The following is a description of a gene set: Mouse Gene Set: GOBP_MEMBRANE_RAFT_ORGANIZATION species: Mus musculus A process that is carried out at the cellular level which results in the assembly, arrangement of constituent parts, or disassembly of membrane rafts, small (10-200 nm), heterogeneous, highly dynamic, sterol- and sphingolipid-enriched membrane domains that compartmentalize cellular processes., and this is the list of marker genes: Pacsin2, Fa2h, Abca7, Rftn1 (raftlin lipid raft linker 1), Lrch4, Clec2i, Emp2, Dlg1, Lat, Naxe, Yjefn3, Flot1, Ptprc, Ilk, S100a10, Anxa2, Cav3, Pmp22, Iqgap1, Gsn, Dock2, Ppt1, Myadm, Npc1, Cav2, Col6a1, Cav1, Colec12, Cln3